The following is a description of a gene set: electronically inferred by orthology from the curated human pathway This event has been computationally inferred from an event that has been demonstrated in another species.<p>The inference is based on the homology mapping from PANTHER. Briefly, reactions for which all involved PhysicalEntities (in input, output and catalyst) have a mapped orthologue/paralogue (for complexes at least 75% of components must have a mapping) are inferred to the other species. studied in species Mus musculus Reactome Pathway: VEGFR2 mediated vascular permeability part of: VEGFA-VEGFR2 Pathway, and this is the list of marker genes: Rictor, Ctnnb1, Cav1, Cdh5, Calm1, Pak3, Pdpk1, Them4, Vav1, Jup